The following is a description of a gene set: Human Gene Set: GOBP_UREA_TRANSPORT The directed movement of urea into, out of or within the cell. Urea is the water-soluble compound H2N-CO-NH2. studied in species Homo sapiens, and this is the list of marker genes: AQP7, AQP9, UMOD, SLC14A1, AQP8, UPK3A, AQP3, AQP11, POU3F3, SLC14A2